Given this list of marker genes Wnt4, Duox2, Fgf2, Sox2 (NCBI Gene Id 20674), Fgf8, Drd2 (dopamine receptor D2, NCBI Gene Id 13489), Pou1f1, Bmp2, Slc6a3, Ghrhr, Lhx3, Ghrh, Hes1, Gsx1, Gata2, Prop1, here is a description of the gene set: Mouse Gene Set: GOBP_ADENOHYPOPHYSIS_DEVELOPMENT The progression of the adenohypophysis over time from its initial formation until its mature state. The adenohypophysis is the anterior part of the pituitary. It secretes a variety of hormones and its function is regulated by the hypothalamus. species: Mus musculus